The following is a description of a gene set: studied in species Mus musculus Any process that stops, prevents, or reduces the frequency, rate or extent of the proliferation of neuroblasts. Mouse Gene Set: GOBP_NEGATIVE_REGULATION_OF_NEUROBLAST_PROLIFERATION, and this is the list of marker genes: Ptn, Bdnf, Pax6, Vax1, Tgfb1, Ctnna1, Btg2, Gata2, Fgfr3, Kctd11, Cd24a, Vsx2, Prox1, Nf1, Trp53, Kifap3